Given this list of marker genes Itsn1, Cttn, Abi2, Nedd4, Baiap2, Yap1, Cyld, Gigyf2, Sh3d19, Garem1, Wbp4, Rabac1, Prpf40a, Csk, Abl1, Baiap2l1, Pfn1, Ccnd1, Tcerg1, Apbb1, here is a description of the gene set: Mouse Gene Set: GOMF_PROLINE_RICH_REGION_BINDING studied in species Mus musculus Binding to a proline-rich region, i.e. a region that contains a high proportion of proline residues, in a protein.